Given this list of marker genes RNU4-2, STIL, STAG2, AHI1, SMC1A, TBR1, CISD2, PLCH1, NDN, TMEM216, CDON, SLC2A1 (solute carrier family 2 member 1), FOXH1, MAGEL2, SIX3, CEP290, WFS1, FGF8, PTCH1, FGFR1, TSEN54, DLL1, GAS1, TECPR2 (tectonin beta-propeller repeat containing 2), GLI2, PSAP, OCA2, NR4A2, INPP5E, SNRPN, SYT1, RPGRIP1L, SHH, FGFR3, ARSL, NODAL, CRIPTO, BICD2, TTC19 (NCBI Gene Id 54902), ZIC2, TGIF1, ATP1A3, DISP1, here is a description of the gene set: Central apnea studied in species Homo sapiens Apnea resulting from depression of the respiratory centers in the medulla oblongata. There is a lack of respiratory effort rather than obstruction of airflow. Human Gene Set: HP_CENTRAL_APNEA